The following is a description of a gene set: Human Gene Set: CERVERA_SDHB_TARGETS_2 from publication Cervera AM, Apostolova N, Crespo FL, Mata M, McCreath KJ (PMID 18519664) Recently, enzymes of the tricarboxylic acid (TCA) cycle have emerged as novel tumor suppressors. In particular, mutations in the nuclear-encoded subunits of succinate dehydrogenase (SDHB, SDHC, and SDHD) cause paragangliomas and pheochromocytomas. Although the mechanism(s) by which disruption of mitochondrial metabolism leads to neoplasia is largely unknown, increasing evidence points to an activation of pseudohypoxia. In this study, we have shown that silencing of SDHB using DNA-based small interfering RNA resulted in major impairments in cellular proliferation, respiration, and a corresponding shift to glycolysis. The levels of reactive oxygen species, however, were unchanged. As expected, hypoxia-inducible factor-1 alpha (HIF-1 alpha) and HIF-2alpha were up-regulated in chronically silenced cells, suggesting that a pseudohypoxic state was attained. In addition, the c-Jun amino-terminal kinase and p38 kinase stress signaling proteins were hyperphosphorylated in SDHB-silenced cells. Microarray analysis showed that >genes were influenced (6-fold or more up-regulation or down-regulation) by silencing of SDHB, confirming the importance of the TCA cycle in cellular metabolism. Examples of dysregulated genes included those involved in proliferation, adhesion, and the hypoxia pathway. Of interest, SDHB-silenced cells had a greater capacity to adhere to extracellular matrix components, including fibronectin and laminin, than control cells, thus suggesting a possible mechanism of tumor initiation. Although transient silencing of the HIF-1 alpha transcription factor in SDHB-silenced cells had little effect on the expression of a subset of up-regulated genes, it partially reversed the adhesion phenotype to fibronectin, pointing to a potentially important role for HIF-1 in this process. species: Homo sapiens Genes present but differentially expressed between Hep3B cells (hepatocellular carcinoma, HCC) with RNAi knockdown of SDHB and control cells., and this is the list of marker genes: NUAK1, SCG5, CTSH, PCOLCE2, FSTL3, HKDC1, MST1, P3H2, F5, TGFB2, PKHD1, MELTF, UBASH3B, MICB, DUSP1, CFB, CXCL5, GPRC5B, TMT1A, ESRP1, GPC4 (glypican 4), DDC, NT5E, SYT12, SLC12A2, AREG, LYPD6, A2M (NCBI Gene Id 2), FAXC, GFOD1, NMI, COL7A1, FMO1, IGDCC3, KIRREL1, PRSS23, OVOL2, IL1RAP, ITPR2, ISX, THBS4 (thrombospondin 4), FXYD2, FBN2, SERPINI1, PRRX1, SIPA1L2 (signal induced proliferation associated 1 like 2), NOTCH3, PAG1, SULT1C2, GALNT3, HS3ST3B1 (NCBI Gene Id 9953), MATN2, LINC02532, VGLL3, IGFBP7, TFAP2A, LRATD2, PAH, APOA1, SH3BGRL, LEPR (leptin receptor), HDAC9, STK17A, CREB5, TTR, CRYBG1, PFKFB3, APOM, NTS, MLF1, TNFSF4, CSGALNACT1, HOMER2 (homer scaffold protein 2), CDH6, SDHB, WLS, AFP, SH3BP5, SERPINE2, SOSTDC1, MOXD1, CYB561, FLRT2 (NCBI Gene Id 9822), SLC26A2, FILIP1L, CXCL8, RAP1GAP2, ATP2B2, ELOVL6, CCNE2, GULP1, CTBP2, MCAM, TMT1B (thiol methyltransferase 1B), GSDME, GAS2 (growth arrest specific 2), SUSD4, CLTB, GJA1 (NCBI Gene Id 7953), PEG3, TF, TNFRSF19, LTBP2, MICAL2, C2, FMO5, CGA, CCN1, DLK1, STEAP1, TMC4, FAT3, CADPS2, MAP3K20, AGTR1